Given this list of marker genes ADRA2B, ABAT, SETD3, GPER1, OXT, ADRA2A, TACR3, TACR2, TACR1, here is a description of the gene set: species: Homo sapiens A process in which force is generated within smooth muscle tissue, resulting in a change in muscle geometry. This process occurs in the uterus. Force generation involves a chemo-mechanical energy conversion step that is carried out by the actin/myosin complex activity, which generates force through ATP hydrolysis. The uterus is a muscular organ of the female mammal for containing and usually for nourishing the young during development prior to birth. Human Gene Set: GOBP_UTERINE_SMOOTH_MUSCLE_CONTRACTION